The following is a description of a gene set: Joint contracture of the hand Human Gene Set: HP_JOINT_CONTRACTURE_OF_THE_HAND Contractures of one ore more joints of the hands meaning chronic loss of joint motion due to structural changes in non-bony tissue. studied in species Homo sapiens, and this is the list of marker genes: SLC35A3, ADAMTSL2, CASZ1, ECE1, PIGL, WDR73, NR4A2, FBN1, FBXW11, SMAD2, SMARCAD1, SLC39A13, GPC3, MAP3K7, ZMPSTE24, CCDC22, CRLF1, GLDN (gliomedin), TBX15, L1CAM, POLR3A, CTCF, ACTG2, SMG9, INF2, LMBR1, HACD1, GNPNAT1, DVL1 (NCBI Gene Id 348497), CAPN3, TGFB2, DLK1, SOX9, COL11A1 (collagen type XI alpha 1 chain), DOK7, CUL4B, SIN3A, POLR3GL, NOD2, MMP23B, HES7, COL1A1, CCN6, NEDD4L, GDF5, LAMB3, H4C9, KMT2A, ROR2, KRT9, LMNA, DLL3, GNPTG (NCBI Gene Id 84572), TGFBR1, CANT1, LUZP1, MBTPS2, PEX6, GON7, MEG3, DDR2, TBR1, UBAP2L, NSD1, CLCF1, NOG, TBC1D2B, CAV1, NDRG1, FGFR3, GPKOW, COG5, TGFB3, ADGRG6, ERCC5, CHST3, TMEM70, GDAP1, FKTN, KAT6B, ASXL3 (NCBI Gene Id 80816), CTDP1, MYH3, GABRD, HNRNPA1, FAT4, LIFR, MAFB, WDR4, TPM2, RPL10, FBXO28, ALX3, IDS, PEX1, KIF5A, MAP3K20, POR, GLI3, GJA1, SMOC1, TGDS, CHRNG, GNPTAB, NLRP3, FGFR1, TGFBR2, FZD2, COL6A1, FLNA, ALX1, KMT2B, MORC2, B3GALT6, MYBPC1, CCN2, GMNN, MESP2, LMX1B, IRF5, CDT1, PAX3, MED12, SMC1A, TNNI2, LARGE1, IGHMBP2, PQBP1, JARID2, CNTN1, TUBB3, AUTS2, HOXD13, BCR, FBXO11, TOR1AIP1, SVIL, RERE, ZDHHC9, IDUA, UROS, PYROXD1, FERMT1, TDO2, KCNK9, RAPSN, PEX5, TCTN3, PSMB8, HSPB1, CDH3, IKBKG, ERCC2, PDPN, SH3PXD2B, TPRKB, HK1, AMER1, DHCR24, HSPG2, EMG1, HINT1, TP63, NUP133 (nucleoporin 133), CCBE1, PDGFRB, NAA10, MED25, EFNB1, YRDC (yrdC N6-threonylcarbamoyltransferase domain containing), ERCC1, KIF21A, SELENON, ARID1B, ORC1, MEGF10, SKI (SKI proto-oncogene), FLVCR1, PRKCZ, KDM5B, KRT14, TWIST2, PORCN, ALG3, SLC26A2, DVL3, SPEN, SYNE1, SCARF2, ADAMTS3, MUSK, GPC4, FBN2 (fibrillin 2), NUP88, COL2A1, TMEM218, PTRH2, MAGEL2, CCR6, CDC6, RAB23, BCOR (BCL6 corepressor), UBE4B, FHL1 (four and a half LIM domains 1), CSGALNACT1, ITGA7, SCN4A, KRT1, ERCC6, SIGMAR1, SUZ12 (SUZ12 polycomb repressive complex 2 subunit), NALCN, MAPK1, WNT5A, COL6A2, LFNG, PDXK, SHH, ORC6, ERI1, KRT16, TUBA1A, TBX2, ANTXR2, PMP22, MKS1, SLC35A2, IPO8, RTTN, DYRK1A, COL6A3, RAB3GAP1, NUP107, TRPS1 (NCBI Gene Id 7227), DHODH, RTL1, TLK2, TBX3, COL11A2, KIAA0319L, TP53RK, NXN, UBA1, PRG4, ACTA1, LAGE3, PLEKHG5, PLOD3, RIPPLY2, SLC18A3, ARPC4, ORC4, DLG5, APC2, TPM3 (tropomyosin 3), EZH2, KCNAB2, PHGDH, COG8, UPF3B, ADAT3, MYL2, KDM5C, ANO5, COL12A1, FGD1, NEFL, ZNF407 (zinc finger protein 407), PIEZO2, CDC45, IL6ST, SPTAN1, MYOD1, XYLT1, ADAMTS15, HLA-DRB1, TNNT3, MEGF8, TRPV4, OSGEP, MMP2, CRKL, OCRL, SLC29A3, PRDM16, MYL11, SMAD3